Given this list of marker genes TMEM260, FOXF1, NODAL, CIROP, WT1, KDM6A, MED12, SMAD2, SMC1A, MYRF, KMT2D, here is a description of the gene set: Partial anomalous pulmonary venous return Human Gene Set: HP_PARTIAL_ANOMALOUS_PULMONARY_VENOUS_RETURN species: Homo sapiens A form of anomalous pulmonary venous return in which not all pulmonary veins drain abnormally. Partial anomalous pulmonary venous return frequently involves one or both of the veins from one lung.